The following is a description of a gene set: from publication Yevshin I, Sharipov R, Kolmykov S, Kondrakhin Y, Kolpakov F (PMID 30445619) studied in species Homo sapiens Genes containing one or more binding sites for (ZNF33A) in their promoter regions (TSS -1000,+100 bp) as identified by GTRD version 20.06 ChIP-seq harmonization. Human Gene Set: ZNF33A_TARGET_GENES, and this is the list of marker genes: VPS53, HARS1, IQGAP2, PHLDB3, ARFIP1, NUDT19, SULF1, SETP21, DLL3, ANKRD13A, HSPA4L, ENSG00000215156, UROD, ST7-AS2, COX16, CKLF-CMTM1, TULP4, SLC39A11, YAP1, WAS, PHB2, SERPINE1, FIG4, POLR2B, SLC37A3, IFT122, CYB5D1, CFLAR, LINC00963, AVPI1, ENSG00000267698, SIPA1L2, CALM3, WDR43, IPP, RPS16P5, C11orf52, C11orf71, ATF3, MACF1, ENSG00000179066, STX4, HMGB1, TFPI2-DT, ZNF567-DT, ZNF155, ZNF570, COQ8B, IGDCC4, FUT10 (fucosyltransferase 10), CHCHD1, SMIM10L1, MT-RNR1, SRP68, RGS20, ECE1, SCUBE1-AS1, STUM, CYP4Z2P, PEX26, MTCH1, RN7SKP192, SLC24A1, ALKBH6, CCNL2P1, GUSBP18, NCOA7, AGPAT1, PPFIBP1, RNF145, DCP1B, MTF2, EWSAT1, RAD23BP2, DNAJB12, STX6, SREBF1, ERVH48-1, ST7, AKR1D1P1, CD22, DNAH14, MAP2K6, ZNF569 (zinc finger protein 569), TRAC, WDR70, TGFBRAP1, CYP2G1P, EMG1, RBM7 (NCBI Gene Id 51120), SHKBP1, ZNF230-DT, PBLD, CCNL1, ODAD1, VTRNA1-2, BRINP2, LINC01897, CTBP2, CFL1P1, SAMM50, NALCN, ERCC1, MIR1273C, LINC02273, CLK3, LIPE-AS1, FNDC3B, N4BP2, ENSG00000201541, GOLGA2P5, PRPF18, ZNF230, MTCO3P12, TMEM127, ZNF221, AK6P1, CDHR18P, ZNF420, MAP2K5, WFDC3, GTPBP3, LUCAT1, EPCIP-AS1, AURKB, NREP, TFAP4, ALDOC, EPB41, GPRC5A, SLC6A12, TK2, FHL1P1, NCAM1, DNAJC28, ENSG00000201346, ENSG00000202231, RNU4-77P, GAPDHP14, MAP3K10, ZSCAN5A-AS1, DNASE1L3, RARA, MIS18A, RHOJ, CKLF, PPP1R9B, RERE, HNRNPA1P64, ATP6V1G1P3, B3GNT4, XPO5, RPL12P32, NUP37, MEGF11, CCT5, NOXO1, VPS13A, PIK3R5, PAXBP1, ENSG00000278356, AAGAB, PSG5, MCAT, CEP170, PDHA1, VN2R1P, LINC02465, SLC19A2, CCDC18, ZNF223, NR2F2-AS1, C2CD5, ENSG00000247416, MIR142HG, NEMP1, MTERF1, ARIH1, RAB33B-AS1, GTF3C2, SH3TC2, SPOP, RAP1GAP2, MKRN2OS, NAA38, RNU6-995P, IRF2BP2, MTHFD1L, SPEF2, MRPL24, NBPF1, NUDT19-DT, DHX40, REV3L, USPL1, AMOTL1, USP9X, GABARAPL1, SRCIN1, TXNDC16, RNA5SP189, GLUD1P3, ZNF224, ZNF225, ZNF30-AS1, CD247, THUMPD3-AS1, ZSCAN5A, ZNF225-AS1, HARS2, LGALS8, CPT2, FTL, GGCT, RN7SL299P, ENTPD4, LINC00662, PHOSPHO1, A4GALT, GSTO1, ECHDC2, ACADM, FHAD1, TRIM33, GTF3C2-AS1, ELOVL2-AS1, SHPRH, SEC62, TUBG2, DNTTIP1, BMS1P4-AGAP5, ITM2A, CCDC86, RUNX1, PTGES3P4, ANO8, KRT19, BMS1P4, MT-TF, GGA1, LRRC37B, FRS3, NDUFA1, EDN2, CADM4, AKT2, DCAKD, SPATA24, RPL37 (ribosomal protein L37), RASSF8 (NCBI Gene Id 11228), LINC00670, FXYD5, RPS26P29, LINC-PINT, KDM6A, ZNF383, RCAN1, TFPI2, ANKRD7, RN7SKP195